Given this list of marker genes MIR16-1, GBA2, SCARB2, HEXA, NEU3, GALC, CEL, GLA, GLB1, ACER3, ASAH1, LCT, GBA1, GM2A, ASAH2B, NEU1, ACER2, NEU4, MIR195, GBA3, ASAH2, NEU2, MIR127, PRKCD, HEXB, ACER1, here is a description of the gene set: Human Gene Set: GOBP_CERAMIDE_CATABOLIC_PROCESS The chemical reactions and pathways resulting in the breakdown of ceramides, any N-acetylated sphingoid. studied in species Homo sapiens